The following is a description of a gene set: Any process that activates or increases the frequency, rate or extent of the chemical reactions and pathways involving steroids. Human Gene Set: GOBP_POSITIVE_REGULATION_OF_STEROID_METABOLIC_PROCESS species: Homo sapiens, and this is the list of marker genes: MIR182, WNT4, PRKACA, ABCG4 (NCBI Gene Id 64137), FGF1, POR, QKI, AGT, STAR, ADM, TNF, IFNG, APOE, AGTR1, ABCG1, CES1, PRKAA1, BMP6, SREBF1, NR1D1, KPNB1, SCP2, NR5A2, CYP7A1, MIR96, FSHB, SCAP, GNAI1, SREBF2, LDLRAP1, PAQR3, APOA1, CGA, DAB2, MAPK1, STARD4, MBTPS2